Given this list of marker genes Sec23b, Trappc2b, Sec16b, Golt1a (golgi transport 1A), Trappc3, Cog3, Golga2, Sec23a, Trip11, Sec31a, Tmed3, Ergic3, Vcp, Stx5a, Copb2, Trappc2l, Tmed7, Tmed9, Vti1a, Arf1, Rnf139, Rint1, Yipf7, Copg2, Steep1, Trappc4, Golt1b, Creb3l2, Copg1, Mia2, Lman2l, Bcap31, Yipf5, Lman2, Stx18, Trappc5, Sec22c, Sec16a, Tmed5 (NCBI Gene Id 74336), Spast, Ykt6, Copa, P4hb, Whamm, Bcap29, Rab1a, Lman1, Cul3, Sec22b, Vapa, Trappc3l, Zw10, Tmed4, Vapb, Yif1a, Ier3ip1, Tbc1d20, Scfd1, Yif1b (Yip1 interacting factor homolog B (S. cerevisiae)), Stx17, Sec31b, Cope, Trappc13, Ergic1, Trappc11, Tmed1, Tmed10, Trappc6b, Hyou1, Use1, Pgap1, Rabggta, Tfg, Ank1, Rangrf, Rabggtb (NCBI Gene Id 19352), Ero1b, Lman1l, Gosr1 (golgi SNAP receptor complex member 1), Ergic2, Yipf4, Rab1b, Tmed6 (NCBI Gene Id 78307), Trappc10, Trappc12, Trappc1, Cnih4, Trappc9, Tmed2, Pef1, Lrrk2, Sec24c, Sar1a, Tex261, Mppe1, Sec24d, Insig1, Arcn1, Surf4, Sec22a, Klhl12, Pdcd6, Nrbp1, Uso1, Erp29, Bet1, Preb, Gas1, Tmed11, Trappc2, Scap, Copb1 (coatomer protein complex, subunit beta 1), Cideb, Sec13, Mia3, Htt, Sar1b, Yipf6, Lmf1, Sec24a, Sec24b, Mapk15, Sorl1, Trappc6a, here is a description of the gene set: studied in species Mus musculus The directed movement of substances from the endoplasmic reticulum (ER) to the Golgi, mediated by COP II vesicles. Small COP II coated vesicles form from the ER and then fuse directly with the cis-Golgi. Larger structures are transported along microtubules to the cis-Golgi. Mouse Gene Set: GOBP_ENDOPLASMIC_RETICULUM_TO_GOLGI_VESICLE_MEDIATED_TRANSPORT